Given this list of marker genes PARP10, CTNNB1, P3H1, BEX3, ADGRB1, BAG5, RELA, FSCB, SVBP, GCLC, SENP2, TSPO, CEP78, U2AF2, DTX3L (NCBI Gene Id 151636), HMG20A, N4BP1, ARRB1, PINX1, PRMT3, USP4, PRKCE, DCUN1D3, SIRT7, CAPN3, HSPA1B, BEX2, PLAA, UBE2B, PARK7 (Parkinsonism associated deglycase), MAD2L1 (NCBI Gene Id 4085), CDKN2A, HDAC8, WNK1, FYN, BAG2, ABL1, PER2, OGT, CEP63, TRIM21, MAD2L2, SQSTM1, GNL3L, PPIA, TRIM44, FLCN, MARCHF6-DT, COPS9, DNAJB2, FBXO5, RPS7, SH3RF2, PRKCG, TAF1, USP44, RPL23 (ribosomal protein L23), UFL1, VPS28 (VPS28 subunit of ESCRT-I), SPRY2, MARCHF7, CAMLG, TTC36, HSPA1A, MAGEA2B, AKT1, RPL11, RPS3, ATG5, GPS2, RPL5, TNFAIP3, ARRB2, IVNS1ABP, CRY1, SPOPL, BEX1, MIR138-1, CDK5, NXN, KLHL40, CRTAP, CAV1, PABPN1L, BEX4 (brain expressed X-linked 4), CHP1, DNAJA1, MINAR1, HMG20B (high mobility group 20B), UBXN1, MIR101-1, PIAS3, MAGEA2, ISG15, GTPBP4, here is a description of the gene set: Human Gene Set: GOBP_NEGATIVE_REGULATION_OF_POST_TRANSLATIONAL_PROTEIN_MODIFICATION Any process that stops, prevents or reduces the frequency, rate or extent of post-translational protein modification. species: Homo sapiens